The following is a description of a gene set: species: Homo sapiens from publication Xie X, Lu J, Kulbokas EJ, Golub TR, Mootha V, Lindblad-Toh K, Lander ES, Kellis M (PMID 15735639) Genes having at least one occurrence of the highly conserved motif M49 CATTGTYY in the regions spanning 4 kb centered on their transcription starting sites. This matches the SOX9 transcription factor binding site V$SOX9_B1 (v7.4 TRANSFAC). Human Gene Set: CATTGTYY_SOX9_B1 Comprehensive identification of all functional elements encoded in the human genome is a fundamental need in biomedical research. Here, we present a comparative analysis of the human, mouse, rat and dog genomes to create a systematic catalogue of common regulatory motifs in promoters and 3' untranslated regions (3' UTRs). The promoter analysis yields 174 candidate motifs, including most previously known transcription-factor binding sites and 105 new motifs. The 3'-UTR analysis yields 106 motifs likely to be involved in post-transcriptional regulation. Nearly one-half are associated with microRNAs (miRNAs), leading to the discovery of many new miRNA genes and their likely target genes. Our results suggest that previous estimates of the number of human miRNA genes were low, and that miRNAs regulate at least 20% of human genes. The overall results provide a systematic view of gene regulation in the human, which will be refined as additional mammalian genomes become available., and this is the list of marker genes: SPTBN5, EPHB6, HDX, DENND2C, LOXL4, HSPG2, CHN1, ADAM15, NAV1, TRIB2, NGFR, APLN, MRAP, LAMA1, MYL3, SLC25A40, SMARCD1, ZMYND8, PRKCH, LRMDA, DDAH2, NDST3, TIAM1 (NCBI Gene Id 7074), TRIM2, DYRK1A, TCF4, SLC4A1 (solute carrier family 4 member 1 (Diego blood group)), SIRT6, PLEKHA1, RADIL, KCNQ1DN, KIF20B, YEATS2, HSD11B1, STAT3, PRDM8, TIA1, KIF1C, KIF1B, CSF3, PATL1, RTL9, BNC2, HYAL2, LINC01101, SYTL2, CHST8, GFRA1, FBXO11, GTF2E2, MARCKS, EIF4EBP2, ZFAND5, HOXB9, AMER1, WNT1, FAM53B, FOXP2, PHC1, NAA38, MEOX1, TLE1, RREB1, OSBP2, ZNF711, HMGN3, IGF2BP1, MAOB, POLB, GNG11, SEPTIN4, BPTF, S100A1, CRMP1, GREB1, HOXA10, MGAT5B, DCX, TPM4, CDC27, ZNF664, GRK5, SEMA6C, BCL2L11, VASH1, MMP1, ZNF436, NT5C2, ZNF362, SLC39A9, RAPH1, GNAO1, ARID1A, OTUD7B, PDS5B, MDFI, GPR85, TRMT2A, SPATS2, ERH, TLCD3B (NCBI Gene Id 83723), SMARCA5, SPAG9, MYO18A, NUFIP2, TBX6, TNPO1, RRM2, MYLK, PAQR4, SCAI, SERINC3, VWF, PICALM, FAM53C, PPP1R16B, PAFAH1B2, CFL2, PMEL, RBM39, FGFR3 (NCBI Gene Id 55546), JAKMIP2, CD151, PHF6, IGF1, PTMA, VAX1, SCD, PDE7A, MITF, MAPK3, CDR2L, EIF3A, PNRC1, CNTF, NEUROD2, CHL1, TRMT9B, DTX1, PLXDC2, PTPN4, CLIC4, CCDC85B, LINC02875 (long intergenic non-protein coding RNA 2875), P2RX3, PAG1, SEPTIN9, ADNP (activity dependent neuroprotector homeobox), HAPLN2, KRT14, CD40LG, DLX1, PMCH, VLDLR, PCDH18, MAP1B, DLG2, SLC26A9, PDIK1L, DLC1, MTSS1, SORBS2, JPT1, EXOC5, TMEM88, RSBN1, CELF3, MAPK8IP1, SOX14, TREX1, NR2F6, ETS1, EIF4E, ELOVL6, RBM14, MFAP5, SLC39A8, B3GALT2, ADCY10, NDST4, PTPN12, IGF2-AS, CNN1, IL17B, SEPHS1, BRD8, SIX1, PNOC, ARF4, NXN, PBX1, GPC2, DOCK4, ADAMTS5, KLF6, CDCA7, SLC6A9, MOSPD2, ZNF710, FOXA1, COLEC10 (collectin subfamily member 10), ITCH, IGF2R, PER2, ORAI3, TBL1XR1, SFRP1, NDST2, BCL11A (NCBI Gene Id 55085), LIN28A, FGF9, CYRIA, TSSK3, ANK3, HMGB1, SUN2, FAM72A, MAP4K4, UBE3A, SNAPC3, ABCF2 (ATP binding cassette subfamily F member 2), KPNA3, AP5M1, CBFA2T2, ARFGEF1 (ADP ribosylation factor guanine nucleotide exchange factor 1), BCL2L1, DAB2IP, KAT6A, OLIG2, DCLK2, TFDP2, RANBP1, CORO1A, CD68, LMO3, CDK2, FBXO28, HHEX, SRGAP1, ACVR2A, ATL1, MBP, PSIP1, PRDM1, TOP1, BMF, INCA1, TRAF4, MAML1, RAB1A, LHX6, BPIFB1, ZNF277, ZFAND3, TUBB2B, ILF2, MLLT6, TUBA1A, ELAVL1, RANBP9, MID1, STMN1, RASSF2, G3BP2, PRKCQ, MPPED2, PCSK2, TMEM132A, GJC2, FGF10, BRPF1, HOXA2 (NCBI Gene Id 3199), MYH2, CALD1, FANCB, CDX1, MYCT1, DMP1, ZCCHC8, TGIF1, MPZ, ZNF521, OLFM1, ARHGEF19, VCL, INHBA, FGD4, DPYSL5, HOXA3, FBXL19-AS1, KCNN2, PCBP4, NIPAL2, ZNF436-AS1, SOX2 (SRY-box transcription factor 2), BASP1, FGFR1, NUMBL, PANK1, SDCCAG8, HOXD3 (NCBI Gene Id 3232), FLI1, ERG, TEAD1, AP1S2, YWHAQ, ZSCAN2, FEN1, CALHM5, H3-3B, BMP5, NDRG2, NUDT3, SLITRK1, TBC1D14, KLK3, ADAMTS6, OLIG3, CDK8, CYB5D1, ABLIM3, RBMS1, HDAC9, PRM1, EGFLAM, BAMBI, SKIDA1, CCDC92, SOX5, TPM3, MN1, PAK2 (p21 (RAC1) activated kinase 2), HMGN1, FAM13C, CD96, ADGRF5, LURAP1L, SPECC1, NASP, CDKN1A, FBXL20, NKX2-2, KLHL13, EHBP1, DMD (dystrophin), YWHAZ, CNN3, CLOCK, MEIS1, TNS2, STAG3, HERC4, MEX3D, FOSL2, TSSK2, NOTCH3, ANKRD11, MYCL, DBF4, PAX3, TMEM258, ZNF8, TNNI1, RDH10, EDN1, PCDH12 (NCBI Gene Id 51294), TRPM3, WEE1